The following is a description of a gene set: Catalysis of the reaction: ATP + AMP = 2 ADP. Mouse Gene Set: GOMF_ADENYLATE_KINASE_ACTIVITY studied in species Mus musculus, and this is the list of marker genes: Ak5, Ak3, Ak1, Ak2, Ak7, Ak6 (adenylate kinase 6), Ak8, Ak4, Gm17949